The following is a description of a gene set: studied in species Homo sapiens Genes having at least one occurrence of the motif NKNTTGCNYAAYNN in the regions spanning 4 kb centered on their transcription starting sites. This matches the CEBPB transcription factor binding site V$CEBPB_02 (v7.4 TRANSFAC). Human Gene Set: CEBPB_02, and this is the list of marker genes: TMPRSS4, ID3, SERPINF1, NOL4L, SYNCRIP, TOP1, RHOB, MED12L, DENND4A, MYO1C, TOB1, UGP2, RAB44, RC3H2 (NCBI Gene Id 54542), CHD2, SPIB, RS1, IP6K2, MMP27, PAFAH2, FGF14, EIF4A2, PTGR3, CPNE4 (NCBI Gene Id 8902), TSHZ3, AQP9, G0S2, EIF4A1, HOXA5, RPS21, PBDC1, ARID1B, TAC1, ONECUT2, BDKRB1, SLC6A4, RBM39, CBX4, VNN3P (NCBI Gene Id 55350), TRIB1 (NCBI Gene Id 80272), ESR1, FBXW7, MBNL1, FGB, SBSN, ASGR1, ZNF217, NFKBIZ, HAVCR1, CSMD3, ASCL2, SLC12A1, FGA, H3-3B, SMAD1, COL4A3, PIP5K1A, NLRP3, BNIP3L, SBF2, PPL, THRA, BMF, SPRED1, NCKAP5, EFNA5, DCAF6 (DDB1 and CUL4 associated factor 6), PITX2, PCTP, PLA2G2E, PER1, CEP120, EDN2, KCNJ13, CIPC, SP8, TMEM104 (transmembrane protein 104), IL1RAPL2, PFN2, COL4A4, SPRY4, STEAP4, PPM1B, TGFB3, PTPN12, CACNB2, MAP3K3, FCER1G, RAB3IP, DBH, CTDSPL2, TRPM1, ZBTB20, UBQLN1, C1QL1, CITED1 (NCBI Gene Id 4435), MAP2K6, ARHGEF38, ITPR3 (inositol 1,4,5-trisphosphate receptor type 3), FOXP1, SMAD6, SOCS2, ZEB2, ANGPT1, NHLH1, RAD23B, H2AJ, SLC25A12, OPN1LW, RUVBL2, CUEDC1, SOX10, PDE4D, KCNJ2, PKNOX2, RPA3, DLX1, MOSPD2, RAB2A, PPARG, TBR1, ADRB2, FMO2, PPP1R3D, CCND2, KPNA3, FIGN, SLIT3, YRDC, C1orf122 (NCBI Gene Id 127687), TCF12, PRLR, KRT23, TRMT10A, SARNP, LEP, LCOR, RIN3, PRR15, BAZ1A, FST, CAVIN2, BCL6, ERF, SMARCA1, MIDEAS, PRDX3, NEK6, FAM217B, CHRM1, NFE2L2, CASS4, ACLY, STX18, TMEM255A, LMO4, SMARCAD1, HOXC13, SOBP, METTL9, SYNJ1, SLC19A3, PCF11, P2RY4, STAT3, CDKL5, WNT5A, LEMD2, S100PBP, ASAH2, HSP90B1, ATP13A4, HECTD4, PHLDB1, MPPED2 (metallophosphoesterase domain containing 2), PHOX2B, NFKBIA, DENND2D, KCNE3, SERPINA7 (serpin family A member 7), SIRPA, PLA2G4A, PDCL, SEPHS2, GLP2R, MEOX2, SKIDA1, TTC39B, MRC2, NAT9, CP, LONRF3, SULF1, PLPP5, ITGA11, TXLNG (taxilin gamma), VCAN, REXO2, DMD, BDNF, SOX5, SERTAD4, NDRG1 (NCBI Gene Id 7998), STEAP2, EHF, ALDH1A2, DUSP1, PALS2, CDKN1B, PDGFRA, CITED4, RASAL2, DYRK3, TGIF1, FRMD5, BUD31, ATAD2, ACAN, PCDH7, ARRDC3, RBPMS (RNA binding protein, mRNA processing factor), SLC7A11, SHKBP1, IL19, GOT1, NFIL3, H2AZ1, ARNT, UBE2E2, CSNK1E, BCL11A, JADE3 (jade family PHD finger 3, NCBI Gene Id 9767), ERLIN1, PRG4, CASK, LINC00670, RRBP1, GPATCH11 (G-patch domain containing 11), RFX4 (regulatory factor X4), KCNH7, HNRNPR, S100A9, CYP24A1, MTF1, IL27 (NCBI Gene Id 246778), MAP4K4, ELAVL2, CCL3, PDAP1, SMIM29, RGR, SMARCA2, DDR2, PDGFRL, ARF6, PDGFB (NCBI Gene Id 5155), TSHZ2, LUZP1, PDE3B, PRR14L, H1-2, GYS1, FOXN3, BNC2 (basonuclin zinc finger protein 2), PPP1CB, LYPD1